The following is a description of a gene set: Human Gene Set: GSE19941_IL10_KO_VS_IL10_KO_AND_NFKBP50_KO_LPS_STIM_MACROPHAGE_DN Bone marrow-derived macrophages were produced from mice lacking IL-10 alone (IL10-def) or mice lacking both IL-10 and the p50/p105 subunit of NF-kB (p50/IL10), and left unstimulated, stimulated with LPS (1 ng/ml) or stimulated with LPS and IL-10 (0.3 ng/ml). Genes down-regulated in macrophages stimulated by LPS: IL10 knockout versus IL10 and NFKB1 knockout. studied in species Homo sapiens from publication Yang HT, Wang Y, Zhao X, Demissie E, Papoutsopoulou S, Mambole A, O'Garra A, Tomczak MF, Erdman SE, Fox JG, Ley SC, Horwitz BH (PMID 21217011), and this is the list of marker genes: DNAJC27, SARM1, MRPL34, SLFN12L, ACD, CIAO1, ALG14, TUSC2, RIC1, PDCL3, TRAT1, NCK1, TOMM22, TDRP, BORCS8, DAXX, CDKAL1, CBR1, NIP7, RPA1 (NCBI Gene Id 6117), FYN, ECHS1, CIB1, CHRM4, IFIT1, TRAPPC5, IPCEF1, CD3G, ODC1, TAF7, C1orf43, LEF1, CD9, NDUFB10 (NADH:ubiquinone oxidoreductase subunit B10), IL22 (NCBI Gene Id 57328), ATP6V1A, CREB3, MYOZ3, NFATC2, RBM8A, GLRX5, MRPL49, NOP16, PRDX3, NSDHL, MXD4, BRDT (bromodomain testis associated), TMT1B, MAN2A1, C2CD2, NDUFA8, CD160, EML4, DCAF13, SNX10, FBXO25, SNX20, ANKMY2, RBM4, RNF114, ATP5MC1, TOX, OAZ2, COTL1, API5, ARHGDIB, NAA16 (N-alpha-acetyltransferase 16, NatA auxiliary subunit), CYBB, LAMTOR5, EXOSC2, ERG28, ISCU, BCL2A1, SLA2, ECH1, KLHL9, NDUFB5, SAP18, PSMD10, BTF3L4, MRPS6, EIF4E, ATP5F1A, GLMP, AKR1B1, HCG4, MLX, TOR3A, TOX2, SDHB, GLO1, FTH1, PIAS2 (protein inhibitor of activated STAT 2), ZFP82, ATP6V1D, HMOX2, HTATIP2, TTC16, EIF3J, ZWINT, PURG, PSMB4, PSMB1 (NCBI Gene Id 5689), TRMT112, BCCIP (BRCA2 and CDKN1A interacting protein), HPCAL1, SKP1, RETREG1 (NCBI Gene Id 96119), RWDD4, DCK, AKAP12, RNF149, C19orf53, PANK1, DHCR24, PPP1CA, PSMD8, GHITM, CELA1, POP5, SLC25A14, PPP6C, COMMD7, CD247, AP3S1, CCDC136, GAB2 (NCBI Gene Id 9846), TM2D3, EDN3, PRDX1, HSDL1, ATP5PO, SUPT4H1, EOLA1, YWHAQ, NSG2, NLK, EPHA1, PTRH1, STARD5, SAC3D1, DDT, RBKS (ribokinase), PFN2, CERS6, AMPD2, VAMP8, BTBD6, CXCR5, NINJ2, OSGEP, IRAK1BP1, UFC1, CD96, CHMP5, SH2D1A, STAMBP, KCTD21, DDX47, CACYBP, ESYT2, COPZ1, C20orf96 (NCBI Gene Id 257109), COX6B1, EIF6, FSTL3, B3GNT2, MSRB2, KCNMB4, IL1R1, ARMC3, SLC35B2, SHQ1, GCG, LPIN1 (NCBI Gene Id 23175), MRPL35, CCL4, LAMTOR4 (NCBI Gene Id 392758), SIN3B, FHDC1, CD68, TMEM176A, HMGCS1, FDFT1, RAB2A, AGTRAP, PSEN1, SLC66A1, CYP51A1, ADRA2B, CXorf38, DPP3, EPSTI1, ORMDL1, PLCD3, GPX1, PDCD1, MSL3, SNAPC2, DYNC2I2